The following is a description of a gene set: part of: Neuronal System species: Homo sapiens Reactome Pathway: Transmission across Chemical Synapses Chemical synapses are specialized junctions that are used for communication between neurons, neurons and muscle or gland cells. The synapse involves a presynaptic neuron and a postsynaptic neuron, muscle cell or glad cell. The pre and the postsynaptic cell are separated by a gap (space) of 20 to 40 nm called the synaptic cleft. The signals pass in a single direction from the presynaptic to postsynaptic neuron (cell). The presynaptic neuron communicates via the release of neurotransmitter which bind the receptors on the postsynaptic cell. The process is initiated when an action potential invades the terminal membrane of the presynaptic neuron.<br> Action potentials occur in electrically excitable cells such as neurons and muscles and endocrine cells. They are initiated by the transient opening of voltage dependent sodium channels, causing a rapid, large depolarization of membrane potentials that spread along the axon membrane.<br> When action potentials arrive at the synaptic terminals, depolarization in membrane potential leads to the opening of voltage gated calcium channels located on the presynaptic membrane. The external Ca2+ concentration is approximately 10-3 M while the internal Ca2+ concentration is approximately 10-7 M. Opening of calcium channels causes a rapid influx of Ca2+ into the presynaptic terminal. The elevated presynaptic Ca2+ concentration allows synaptic vesicles to fuse with the plasma membrane of the presynaptic neuron and release their contents, neurotransmitters, into the synaptic cleft. These diffuse across the synaptic cleft and bind to specific receptors on the membrane of the postsynaptic cells. Activation of postsynaptic receptors upon neurotransmitter binding can lead to a multitude of effects in the postsynaptic cell, such as changing the membrane potential and excitability, and triggering intracellular signaling cascades., and this is the list of marker genes: HTR3D, LIN7A, ADCY2, RASGRF2, CHRNA5, GABRA3, SLC6A1, GAD1, TUBA4A, GNG13, PRKAB2, LIN7C, GNG8, GNGT2, SLC32A1, KCNJ3, ALDH2, GLS, GRIA4, GLRA1, AP2M1, KCNJ2, PRKAR1B (NCBI Gene Id 645590), TOMT, TUBB4A, TSPOAP1, SLC18A3, SLC18A2, PLCB1 (NCBI Gene Id 23236), SLC1A6, GABRA5, SYT1, SLC6A13, CHRNA4, CHRNB3, GRIA2, PPFIA3, GAD2, GRIN3B, PRKCG, ADCY4, MAOA, CHRNA9, TUBA4B, PRKAG2, GNB3, CAMK2B, GRIK5, CHRNA2, CACNG8, GLRB, SLC5A7, GNAI2, GLUL (glutamate-ammonia ligase), PPFIA4, SRC, GABRR2, GLS2, GABRG3, PRKACG, PRKACB, GABRR1, NRGN, GNG4, CACNG2, GIT1, ACHE, KCNJ9 (NCBI Gene Id 7820), GRIK3, CAMK2D, PRKAR2B, NCALD, CHAT, PPFIA2, CAMK2G, BCHE, CHRNB2, CHRNA3, TUBA3C, CAMKK1, TUBA1A, GNG7, NEFL, CACNB4, AKAP5, GNB1, GABBR1, PRKAG1, GNAT3, RIMS1, LRRC7, GNG10, TUBB4B (NCBI Gene Id 10383), DLG4, GNB2, CACNB3, GABRA4, EPB41L1, GABRG2, SLC17A7, ADCY5, CHRNA6, SLC6A3, KIF17, TUBB2B, SLC22A2, GRIP1, CHRNB4, PRKAR2A, ADCY8, KCNJ5, TUBB1 (tubulin beta 1 class VI), MAPK1, DLG1, CACNA2D2, GRIN1 (glutamate ionotropic receptor NMDA type subunit 1), ALDH5A1, PPM1F, GNAI1, CHRNA1, KCNJ10, COMT, UNC13B, TUBA1B, SLC6A12, NRG1, TUBB2A, RAB3A, CACNA2D3, SLC1A2, PLCB2, SLC1A3, PRKX, DLG3, AP2A2, GNG11, GLRA2, CPLX1, STX1A, GRIN3A, GABBR2, SYN1, ADCY3, APBA1, CREB1, TUBA1C, CAMK1, NAAA, GNB4, ERBB4, ARL6IP5, ADCY9, ADCY7, CHRNA7, CHRND, HTR3B, RPS6KA2, AP2S1, GNG5, PRKAB1, PRKACA, AP2B1, ABAT, GRIA3, NPTN, GABRA6, TUBB8B, KPNA2, CACNA1B, GABRB2, PRKAA1, SLC1A7, ACTN2 (NCBI Gene Id 88), HRAS, CHRNG, CHRNE, CALM1, SYN2, HSPA8 (NCBI Gene Id 3312), RASGRF1, NSF, CASK, TUBA3D, GNB5, SLC22A1, GABRR3, PRKAA2, KCNJ6, CACNG3, CAMK4, TUBB6, KCNJ15, PDPK1, DNAJC5 (DnaJ heat shock protein family (Hsp40) member C5), MDM2, GABRA2, NRAS, CAMKK2, ARHGEF7, SLC6A4, GNG3, CACNB2, TSPAN7, GABRQ, PICK1, TUBA8, CAMK2A, ADCY6, GNG12, GNGT1, HTR3E, NBEA, GNG2, RPS6KA3, PRKAR1A, TUBB3, PRKCB, RAC1, KRAS, GRIN2C, CACNA1E, GRIK1, RPS6KA1, GRIP2, MYO6, GRIK2, MAPK3, LIN7B, GRIN2D, CACNA1A, KCNJ4, DLG2, CACNB1, CACNA2D1, PPFIA1, VAMP2, CACNG4, GNAL, GABRB3, KCNJ16, HTR3A, MAPT, GLRA3, TUBAL3, HTR3C, ARHGEF9, RPS6KA6, AP2A1, SLC38A2, STXBP1, KCNJ12, SLC1A1, GRIK4, SLC38A1, SNAP25, PRKAG3, ADCY1, GRIN2A, GNAI3, TUBB8, PPM1E, TUBA3E, GABRB1, GRIA1, PLCB3, GRIN2B, SLC6A11, GABRA1, SYN3, PRKCA